Given this list of marker genes Slc16a1, Nop56, Ctla2a, Xpo1, Fosl1, Top1, Tubb2a, Tsc22d3, Cd44, Bzw1, Itga5, Cebpb, Hsph1, Ifi204, Samhd1 (SAM domain and HD domain, 1), Rras2 (NCBI Gene Id 97407), Arl4d, Por, Slc7a6, Ppa1, Prr5, Srxn1, Il1rl1, Fgl2, Prdx6 (NCBI Gene Id 320807), Ucp2 (NCBI Gene Id 22228), Scd1, Slc23a2, Uap1, Sdc1, Ppp1r2 (NCBI Gene Id 74865), Hmga2, Rcl1, Plac8, Gsto1, Klf5, Tiam1, Ereg (NCBI Gene Id 269673), Vdr, Tead4, here is a description of the gene set: species: Mus musculus from publication Burton GR, Guan Y, Nagarajan R, McGehee RE Jr (PMID 12137940) Cluster 3: genes maximally expressed at 8 hr time point during differentiation of 3T3-L1 fibroblasts into adipocytes in response to adipogenic hormones. The molecular mechanisms that regulate cellular differentiation during development and throughout life are complex. It is now recognized that precise patterns of differentially expressed genes ultimately direct a particular cell toward a given lineage and many of these are regulated during the earliest stages of differentiation. Using a microarray-based expression analysis, we have examined gene expression profiles during the first 24 h of 3T3-L1 adipocyte differentiation. RNA was isolated at times 0, 2, 8, 16, and 24 h following stimulation of differentiation and hybridized in duplicate to high density Affymetrix microarray gene chips containing a series of 13,179 cDNA/expressed sequence tag (EST) probe sets. Two hundred and eighty-five cDNA/ESTs were shown to have at least a fivefold change in expression levels during this time course and both hierarchical and self-organizing map clustering analysis was performed to categorize them by expression profiles. Several genes known to be regulated during this time period were confirmed and Western blot analysis of the proteins encoded by some of the identified genes revealed expression profiles similar to their mRNA counterparts. As expected, many of the genes identified have not been examined in such a critical time period during adipogenesis and may well represent novel adipogenic mediators. Mouse Gene Set: BURTON_ADIPOGENESIS_PEAK_AT_8HR